Given this list of marker genes Atrn, Pcdha2, Golga1, Zfpm2, Perp, Vma21, Sema5a, Slc39a12, Gabpa, Top1, Man2a1, Spred1, Lars2, Dyrk1a, Shc2, Nsd2, Setd5, Drd5, Dio2, Map4k4, Onecut2, Pcdhac2, Tmem245, Cntn2, Xirp2, Gml2, Ctxn1, Lancl1, Sh2d5, Pik3r3, Arhgap32, Slc16a4, Meikin, Wdr38, Pcdha6, Ptger2, Pcdha10, Klhdc8b, Plxna4, Kidins220, Usp48, Trpm3, Cdc6, Mtf2, Mpp7, Adam9, Ublcp1, Unk, Chka, Cep170, Slx9, Prim1, Lcorl, Blcap, Ube2h, Wnt8b, Mlec, Btbd3, Sun1, Rpl22, Tshz2, Pcdh7, Gml, Kpna4, Rai2, Gosr2, Selenok, Magi3, Arhgap10, Fchsd2, Rab8b, Pcdha7, Slc35b4, 6430550D23Rik, Pcdha9, Eif1a, Foxo3, Ppil1, Pcdha4, Ino80d, Slc22a23, Pcdha5, Qser1, Calml3, Cramp1 (cramped chromatin regulator 1), Sema3c, Dolpp1, Smad2, Krt26, Gpcpd1, Depdc5, Pcdha12, Pcdhac1, Grk3, Pcdha11 (NCBI Gene Id 12942), Pcdha3, Lmod3, Sprr3, Rnf169, Rab27b, Gpr55, Gan, Fbxo32, Slc35e1, Rsl24d1, Cdk6, Tmem164, Kitl, Fn3k, Pcdha1, Slc4a8, Myo5a, Zcchc9, Ocrl, Atg4a, Heca, Skint4, Csnk1g1 (casein kinase 1, gamma 1), Pkn2, Cnst, Rnf220, Zfp819, Reps2, Mras, Zfand5, Slf2, Lpcat2b, Dab2, Usp31, Ctnna1, Asap1, Lacc1, Gnas, Fut9, Zeb1, Otud4, Cep97 (NCBI Gene Id 74379), Polg, Thumpd3, Zfp367, Dnajb11, Rala, Scn8a, Il5, Rab39, Cul4b, Cstf3, Btbd1, Adipor2, Caprin2, Mlst8, Hps4, Pea15a, Slc4a4, Bbx, Rasgef1a, Mis18bp1, Gtf3c4 (NCBI Gene Id 99180), Eif4g2, Chchd6 (coiled-coil-helix-coiled-coil-helix domain containing 6), Gpr161, Gpr156, Npc1, Dapp1, Tada2b, Fam217b, here is a description of the gene set: from publication Chen Y, Wang X (PMID 31504780) species: Mus musculus Genes predicted to be targets of miRBase v22 microRNA mmu_miR_7011_3p in miRDB v6.0 with MirTarget v4 prediction scores > 80 (high confidence targets). Mouse Gene Set: MIR_7011_3P